The following is a description of a gene set: Human Gene Set: HP_APLASIA_OF_THE_ULNA Aplasia of the ulna studied in species Homo sapiens Missing ulna bone associated with congenital failure of development., and this is the list of marker genes: TBX5, ESCO2, LMBR1, WNT7A, TBX3